Given this list of marker genes DPP4, HHLA2, CD320, CD24, CCR7, SPN, CD86, EFNB2, CSK, TMIGD2, CD40LG, CCL19, TNFSF4, TNFRSF14, ICOS, MAP3K8, CD5, LGALS8, EFNB1, SRC, LGALS1, LILRB2, CD81, AKT1, YES1, VAV1, PDCD1LG2 (programmed cell death 1 ligand 2), CD274, CCL21 (NCBI Gene Id 6366), TNFRSF13C, EFNB3, PTPN11, CD28, KLRK1, KLRC4-KLRK1, CAV1, TNFSF13B, LCK, TNFSF14, LYN, CD3E, CARD11, PIK3CD, FYN, MTOR, CD80 (CD80 molecule), PDPK1, PTPN6, LILRB4, CD160, here is a description of the gene set: Human Gene Set: GOBP_LYMPHOCYTE_COSTIMULATION studied in species Homo sapiens The process of providing, via surface-bound receptor-ligand pairs, a second, antigen-independent, signal in addition to that provided by the B- or T cell receptor to augment B- or T cell activation.